Given this list of marker genes Astn2, Syt2, Itpr3, Adap2, Adap1, here is a description of the gene set: Binding to inositol 1,3,4,5 tetrakisphosphate. Mouse Gene Set: GOMF_INOSITOL_1_3_4_5_TETRAKISPHOSPHATE_BINDING studied in species Mus musculus